The following is a description of a gene set: species: Mus musculus electronically inferred by orthology from the curated human pathway part of: Axon guidance Reactome Pathway: EPH-Ephrin signaling This event has been computationally inferred from an event that has been demonstrated in another species.<p>The inference is based on the homology mapping from PANTHER. Briefly, reactions for which all involved PhysicalEntities (in input, output and catalyst) have a mapped orthologue/paralogue (for complexes at least 75% of components must have a mapping) are inferred to the other species., and this is the list of marker genes: Actr3, Itsn1, Ephb1, Epha7, Fyn, Efnb2, Arpc4, Mmp2, Epha2, Efna2, Ephb3, Sdcbp, Grin2b, Efna5 (ephrin A5), Arpc5, Cdc42, Rasa1 (NCBI Gene Id 218397), Ngef, Efnb1, Efna4, Ephb6, Actr2, Psenen (presenilin enhancer gamma secretase subunit), Grin1, Yes1, Ephb2, Ptk2, Arhgef7, Efnb3, Ephb4, Psen1, Pak3, Hras, Arpc2